Given this list of marker genes Cdh24, Cadm2, Pvr, Amot, Cdh10, Arhgef6, Pard6g, Cdh12, Adam33, Plec, Cdh9, Ang, Parvb, Nectin1, Prkci, Itgb1, Flnc, Cadm1, Cdh4, Pxn, Fermt2, Col17a1, Ctnnb1, Cdh11, Parva, Nectin2, Ilf3, Sdk1, Actg1, F11r, Ctnna1, Sp1, Zeb2, Megf6, Cdh13, Vasp, Tesk1, Cdh6, Cd151, Fblim1, Itgb4, Actn1, Ilk, Jup, Cdh15, Pard6b (par-6 family cell polarity regulator beta), Actb, Cdh5, Ctnnd1, Cdh2, Dst, Adam19, Nectin3, Nectin4, Angptl4, Cdh8, Cdh7, Krt14, Rsu1, Cdh17, Pard3, Itga6, Cdh18, Afdn, Krt5, Flna, Lims1, Hoxc8, Cadm3, Pard6a, Sdk2, Cdh3, Lims2, here is a description of the gene set: Cell junction organization studied in species Mus musculus Mouse Gene Set: REACTOME_CELL_JUNCTION_ORGANIZATION